Given this list of marker genes Gstt2, Gstt1, Gstm7, Gclc, Gsr, Ggt1, Gsta1, Gss, Anpep, G6pdx (glucose-6-phosphate dehydrogenase X-linked), Gstm2, Gpx4, Oplah, Gpx2, Gpx1, Idh1, Gpx3, Gclm, Ggt5, here is a description of the gene set: Mouse Gene Set: WP_GLUTATHIONE_METABOLISM Glutathione metabolism studied in species Mus musculus